Given this list of marker genes MEF2C, RAD52, TRA2B, CRK, SOCS7, PHF12, HYCC2, GPCPD1, TBL1XR1, PTPN13, EPHA4, YTHDF3, MAP1B, MORF4L2, L3MBTL3, PRDM2, CDK14, THOC1 (NCBI Gene Id 9984), MYLIP (NCBI Gene Id 29116), KMT2A, EIF3A, SNIP1, SP8, TWF1, SP3, MECP2, COPS4 (COP9 signalosome subunit 4), RAB1B, SOX6, CA10, MIER3, SON, NBEA, CPEB1, FOXJ3, CMPK1, ARRDC3, SPATS2L, KLF12, IGF1 (insulin like growth factor 1), TULP4, PRICKLE2, H3-3A (H3.3 histone A), HNRNPK, SMNDC1, TM9SF2, AGO1, ZDHHC22, PTTG1IP, C6orf120, TM9SF3, RYBP (RING1 and YY1 binding protein), GABRB3, LDB1, TIPARP, CELF1, PHF20L1, ST8SIA3, ACVR2A, KANSL1, AMMECR1 (AMMECR nuclear protein 1), GOLT1B, OGT, TMEM97, HDHD2, SLITRK5, GID4, AKIRIN2, AMOTL2, RB1CC1, MAP3K2, TP53INP2, H3-5, UNC45A, FZD7, USP15, TJP1, ARHGEF7, FAIM2, SRGAP1, NF2, HTR2C, ZFR, SSPN, KBTBD6, ARHGEF9, ABCC12, ITGA6, PPP3R1, SLC31A1, TPM3, FAM222B, PTPRG, DCUN1D3, SATB2, AMOT, LIN54, JADE3 (NCBI Gene Id 9767), FLRT2, ZNF541, LDLRAD3, GRID1, MRAP2, CELF2, SPECC1, FNDC3A, NRXN1, STRIP2, KRAS, RAB2A, PRKD1, CDH2, SEL1L, ZNF532, PKD1L2, OAZ2, CDKN1B, TEX2, ITM2B, KALRN, RAP2C, NEDD4L, HTR2A, FHIP2B, SPTSSA, CDK12, GLDC, FRAS1, PCCA (propionyl-CoA carboxylase subunit alpha), MXI1, COPS8, KIAA0408, GABARAPL2, GOSR1, RAB22A, PRDM8, COQ10B, ARK2N, NCOA1, KPNA4, F13A1, FAM120A, H3-3B, PDE1B, ERLIN1, CCDC3, CARMIL1, PRP4K, EXTL2, SGCD, DICER1, ETV1, CAMK2G, POU4F1, GPR85, TAFA1, CREB5, PAN3, OLIG3, TNFRSF12A, ZIC3, SOCS5, CXXC4, EIF4G2, ABTB3, BMP1, GAD1, NSRP1, FOXK1, CPXM2, GRPEL2, SP4, DENND6A, here is a description of the gene set: Genes having at least one occurence of the motif GCATTTG in their 3' untranslated region. The motif represents putative target (that is, seed match) of human mature miRNA hsa-miR-105 (v7.1 miRBase). species: Homo sapiens Human Gene Set: GCATTTG_MIR105